The following is a description of a gene set: Human Gene Set: HP_THUMB_CONTRACTURE studied in species Homo sapiens Lack of full passive range of motion (restrictions in flexion, extension, or other movements) of the thumb joint resulting from structural changes of non-bony tissues, such as muscles, tendons, ligaments, joint capsules and/or skin. The term camptodactyly is used if the distal and/or proximal interphalangeal joints are affected. Thumb contracture, and this is the list of marker genes: L1CAM, MEG3, BMP4, RTL1 (NCBI Gene Id 651665), DLK1, ECE1